The following is a description of a gene set: In the present study we used Affymetrix oligonucleotide microarrays to produce gene transcription profiles for the major leukocyte types in humans. This comprehensive dataset enabled us to not only establish which genes were expressed in each leukocyte type, but also which genes were expressed in each subset after activation. The used of a comprehensive dataset of gene profiles from all the major human leukocyte subsets enabled a novel and powerful means for identification of genes associated with single leukocyte subsets, or different immune paradigms. species: Homo sapiens from publication Jeffrey KL, Brummer T, Rolph MS, Liu SM, Callejas NA, Grumont RJ, Gillieron C, Mackay F, Grey S, Camps M, Rommel C, Gerondakis SD, Mackay CR (PMID 16474395) Human Gene Set: GSE3982_BCELL_VS_TH2_UP Genes up-regulated in comparison of B cells versus Th2 cells., and this is the list of marker genes: HOXC4, SLC15A3, SMPD2, VAV3, IGLL3P, KPNA1, POMZP3, KLHL24, FCN1, HS3ST1, H2AC18, CCDC102B, KLRK1, TPP1, GPR27, CDK14, STOML1, PNRC1, RAPGEF5, MAML1, TULP4, FOXL2, TBC1D8, ZNF440, RUBCNL, YBX3 (NCBI Gene Id 8531), SLC25A4, SPATA6L, GABARAPL2, SIDT1, FCGR2C (Fc gamma receptor IIc (gene/pseudogene)), MYO15B, LYZL6, AQP3, ZHX3, TMEM80, NPPC, TCIRG1, ZKSCAN7, ABCB9, ACP5, TMEM268, LYL1 (LYL1 basic helix-loop-helix family member), SLC15A1, PARP16, ZNF839, GATM, PLPP3, JADE2, HBP1, VCL, IGKC, APOBEC3G (apolipoprotein B mRNA editing enzyme catalytic subunit 3G), RNF39, TNFSF13, IL6, MEST, NPVF, FGD2, PIK3IP1, DENND3, CD207, HDAC9, PPFIBP2, N4BP1, DGKD, GVINP1, ZKSCAN4, ARHGEF10, NUP210 (NCBI Gene Id 79985), MCL1, ZZEF1, FAM193A, SLC7A7, LIN37, IRF9, SGSH, PHKB, ZNF239, SCN2B, MICALL1, C4orf19, UPK3A, WFDC1, ARL4A, CD48, YIPF1, TCF7, TCTN1, ELAVL2, TENT5C, INAVA, KIAA0319, DPEP2, CHMP7, SH2D3A, LMO2, TMEM127, PKIG, ZBTB5 (NCBI Gene Id 9925), SIGLEC5, FCHSD2, DAZAP2, DUSP1, RIN1, MAPK8IP3, LTA4H, HCP5, MYH3, PRSS16, RBM4B, PODXL, HESX1, BPI, MEF2C, MX2, CYRIA, RASGRP3, MSL3, PIP4K2B, PLEKHF2, SLC2A10, BBS1, TLR7, NT5E, SLC41A3, RABGEF1, DUSP22, GPR21, HMG20A, RAB36, NFX1, KDM2A, IGHD, GFRA2, HLA-DRB1, C11orf71, GOLGA3, PRKAR2B, AP1G2, EFCAB14, CTBP2, IFNGR2, TSPAN3, ADAM28, ENTR1, TXNDC15, KIF16B, C1orf115, ZBP1, PSME1, ZSCAN18, TBC1D13, UBAC1, HLA-DPA1 (NCBI Gene Id 7935), TMUB2, DUS2, VPS52, TFEB, RAB6A, KLF12, C10orf95-AS1, KCNJ1, HLA-DOB, HLA-DRA, ZNF586, FAM30A, NAA40, PPP3CC, RASGRF1, CASP4, JADE3, GLUL, CREBBP, KIF25, GARNL3, TCFL5, P2RX5, IFIT1, GLDC, TAGLN, CLCA4, PDLIM1, LYSET, PHC3, BASP1, ATPAF2, DPPA4, IRF8, EPN2, KDM7A, PTGS1, RAF1, TRAPPC2, SLC35E1, CXCR2, MIA3